Given this list of marker genes Slc28a2b, Slc29a2, Slc29a1, Slc28a2, Slc29a3, here is a description of the gene set: The directed movement of the purine ribonucleoside inosine, also known as hypoxanthine riboside, into, out of or within a cell, or between cells, by means of some agent such as a transporter or pore. Mouse Gene Set: GOBP_INOSINE_TRANSPORT species: Mus musculus